The following is a description of a gene set: Mouse Gene Set: GOBP_CELLULAR_RESPONSE_TO_ENDOGENOUS_STIMULUS Any process that results in a change in state or activity of a cell (in terms of movement, secretion, enzyme production, gene expression, etc.) as a result of a stimulus arising within the organism. studied in species Mus musculus, and this is the list of marker genes: Fam114a1, Wnt7a, Hcrtr2, Cnot1, Tgfbr3l, Nucb2, Ctbp2, Ubr5, Etv2, Cdc5lrt8, Mtcl2, Uba5 (ubiquitin-like modifier activating enzyme 5), Camk2a, Ceacam2, Itga8, Lrrc32, Lrp8, Glp1r, Tyk2, Smurf2, Col1a2, Heyl, Rock2, Fbxl15, Kcp (NCBI Gene Id 333088), Ywhag, Hmga1, Socs3, Pak1, Nr3c1, Crh, Pkm, Pgr, Ros1, Crim1, Smurf1, Ehd4, Scnn1b, Lrit3, Raf1, Abhd2, Etnppl (ethanolamine phosphate phospholyase), Col4a2, Fermt1, Sphk1, Grem1, Mir486, Fgf7, Ffar3, Reg1, Hyal2, Pdgfb (platelet derived growth factor, B polypeptide), Gpt, Cga (NCBI Gene Id 12640), Daxx, Itgb6, Ero1a (endoplasmic reticulum oxidoreductase 1 alpha), Strap, Flrt2, Neo1, A1bg, Pck1, Gpr155, Ptk2, Mst1r, Rab35, Ncoa1 (NCBI Gene Id 17977), Gpr21, Ptprf, Ireb2, Ngly1, Mir23a, Msx1, a, Cdc5lrt10, Zmpste24, Gpc1, Foxc1, Cav2, Jak3, Rbm14, Gdnf, Gdf6, Greb1l, Ghsr, Vsir, Ptger2, Casp9, Lep (NCBI Gene Id 16846), Cckar, Cyp1b1, Npffr1, Ctnnb1, Ncor2, Lats2, Mir206, Anxa1, Fkbp4, Dlx1, Lpin1, Stat5b, Nkx2-1, Pdpk1, Mir675, Adam17, Csrp3, Prkcb, Rap1gap, Irs1, Comp, Uchl3, Ccn1, Zfp703, Pde4d, Opa1, Rab14, C2cd5 (NCBI Gene Id 77314), Actr3, Ucp2, Pagr1a, Spry2, Aldh1a2, Stat3, Slit3, Agtr2, Rhoq, Sstr2, Ltk, Prmt2, Tmf1, Grem2, Ccl5, Rela, Klf4, Sik2, Sp1, Twist1, Trarg1, Trp63, Mertk, Sfr1, Fgf17, Dand5, Atp5f1a, Rarb (retinoic acid receptor, beta), Ephb1, Magi2, Rxrb, Ppara, Cdkn2b, Ifnb1, Aspn, Park7, Mup5, Mus81, Ppard, Rasl11b, Bmi1, Ppp3ca, Dbn1, Rps6kb1, Gclm, Tmem100, Fgf20, Chrd, Sos2, Bmpr1b, Hmgcs2, Wnt1, Sh3gl2, Socs7, Fez1, Spred1, Atf2, Kdm6a, Adam9, Cnot3, Lancl2, Pip4k2c, Cflar, Appl2, Mir219a-2, Wasf1, Veph1, Bex1, Tmem108, Cpeb1, Mir207, Ugt1a6a, Igf2, Mir297-1, Gnai2, Chst11, Dnaaf4, Zdhhc17, Irs3, Gcg (NCBI Gene Id 14526), Mir125a, Yes1, Dkk1, Mup3, Tmprss6, Gpr150, Acap2, Adrm1, Mgarp, Pik3r2, Bmpr1a, Col6a1, Socs2, Lemd2, Itga3, Pitx3, Cst11, Hnrnpu, Zeb2, Ark2c, Epha5, Ddr2, Car2, Blvrb, Fuz, Gab1, Becn1, Rgmb, Il12b, Clock, Acvr1, Ppargc1a, Crebbp, Sost, Dcn, Srebf1, Lncbate10, Mir219a-1, Nr5a1, Slc27a4, Mcm7, Flcn, Zfyve27, Kdm5b, Ahsg, Cul7, Ndst1, Aqp1, Prkaa1, H2az1, Tgif1, Il17f, Lbh (limb-bud and heart), Robo1, Ctsh, Wfikkn1, Lrp1 (NCBI Gene Id 16971), Ntf3, Csnk1e, Tab1, Efna5, Gria2, Fgf3, Ddx17, Inhbb, Snx25, Elapor2, Adamts7, Peg10, Mn1, Usp8, Lpin2, Mir145b, Ufsp2, Epha8, Nr5a2, Kif16b, Kmt2e, Acbd7, Pou4f2, Vdr, Bglap3, Slc2a4, Cd109, Npas4, Spry1, Zfp128, Cdkn1c, Vtn, Il12a, Fgf15 (fibroblast growth factor 15), Lpxn, Rack1, Phex, Notch1, Cd59a, Zbtb7a, Il17a, Mapk1, Furin, Creb1, Acvr2a, Mef2c, Acvr2b, Ep300, Rhoa, Mir138-2, Phox2b, Trim63, Bmal1, Foxh1, Med1, Calcoco1, Mirlet7f-2, Smarcc1, Zdhhc16, Zfp451, Megf8, Zfyve9, Fkbp1a, Mirlet7e, Smpd3, Iqgap1, Mir192, Nr4a1, Rangap1, Safb, Sstr5, Ints9, Akap8 (NCBI Gene Id 67462), Cat, Cnmd, Zmiz1, Fbp1, Ski, Fzd1, Or51e2, Socs1, Safb2, Hnrnpk, Zcchc12, Pdgfra, Snw1, Vamp2, Ghr, Sos1, Taf7, Dsg4, Cxcl13, Gdf15, Tgfbr3, Slc2a10, Mir195a, Micall1, Prkcq, Cul3, Brms1, mt-Nd3, Mir181d, Acsl1, Ufm1, Lats1, Ndnf, Cad, Mir125b-1, Npffr2, Nr2c1, Nr4a3, Esr1, Rara, Mir708, Epha1, Dnai1, Ext2, Mir494, Nr1d2, Fbn2, Git1, Tgfbr2, Xcl1, Mir338, Gprin3, Ramp3, Hhip, Mup1, Pde3b, P2ry4, Pdcd5-ps, Kit, Flrt3, Spon2, Gdf3, Zfp764, Pin1 (peptidyl-prolyl cis/trans isomerase, NIMA-interacting 1), Gck, Pax9, Epha2, Kat2a, Zfp747l1, Itgb5, Sox5, Cyfip1, Ptprd, Ngf, Rb1, Fam20c, Ppp1r9b, Usp26, Phb1, Rarg, Cdc5l, Tns2, Mirlet7b, Ramp1, Frs2, Selenon, Snx6, Lrg1, Dstyk, Lef1, Mir147, Hgf, Lrp2, Brca1, Kank1 (KN motif and ankyrin repeat domains 1), Kat2b, Itgb1bp1 (NCBI Gene Id 16413), Eif4e, Sra1, Ptgdr, Arid4b, Ing1, Pde3a, Fech, Braf, Parp1, Cd63, Hoxa13, Ntf5, Has1, Sva, Hjv, Nedd4, Cdc5lrt1, Tob1, Arid1a, Klb, Th, Nodal, Bcar1, Otop1, Cdh3, Adamtsl2, Pdk4, Hes1 (hes family bHLH transcription factor 1), Avpr2, Asns, Ift80, Rasa1, Rps3, Nrxn1, Cav3, Map2k5, Bmp5, Stub1, Zeb1, Map3k1, Adra2a, Trp53, Rac1 (Rac family small GTPase 1), Atp7a, Ext1, Skor2, Padi2 (NCBI Gene Id 230871), Agtrap, Ncf2, Baiap2, Sox6, Cited2, Acta2, Prkaca, Ncoa2, Pax8, Vps54, Tcf7l2, Gphb5, Foxd1, Ptprj (NCBI Gene Id 98976), Casr, Tnfsf4, Crhr2, Xbp1 (X-box binding protein 1), Lepr, Epn2, Cyp7b1, Srarp, Bbs2, Cask, Foxo1, Ptpn12, Cry2, Cer1, Hmga2, Mir493, Prkca (NCBI Gene Id 18750), Prdm14 (PR domain containing 14), Scnn1g, Gata5, Smoc2, Ncor1, Rab31, Sap30, Arap1, Cyp26a1, Ucp3, Coro1b, Mmrn1, Lgals9, Epha7, Erbb4, Sgk1, Pelo, Cep57, Ptpn2, Fbxo32, Ccbe1, Ecsit, Gdf2, Ntrk3, Ntrk2, Bmncr, Gfra1, Onecut2, Adissp, Oxtr, Sst, Mir103-1, Tac1, Wt1, Crkl, Nrp2, Emd, Fam89b, Adipor2, Dnmt1, Ogt, Stxbp4, Akt1, Dll1, Blvra, Npnt, Npc1, Cadm4, Sgcb, Dlx5 (NCBI Gene Id 13395), Fgf21, Churc1, Nr1h3, Ptgfr, Myo5a, Fgf12, Vps18, Leprotl1, Vps11, Mup2, Myog, Tmem204, Naip1, Ddx5, Mkks, Foxo4 (forkhead box O4), Sox10, Akr1c19, Stmn2, Smad9, Mir148a, Mir142, Gata4, Tnrc6c, Axin2, Fgf4, Map1b, Cdc5lrt7, Cuzd1, Ppp5c, Abl1, Notch2, Bloc1s6, Zfp764l1, Mup11, Smad7, Rab13, Sstr1, Cited1, Ilk, Jun, Acvr1b, Irf1, Gnrhr, Gstp1, Nfe2l2 (NCBI Gene Id 98874), Ncl, Tnfaip6, Ins1, Atp2b1, Mir26b, Ndel1, Epha6, Fgf16, Pax6, Sorl1, Cdh5, Pxn, Cib1, Ptpre, Glp2r, Rhod, Insrr, Gata6, Bambi, Vwc2l (NCBI Gene Id 320460), Mtmr4, Shc1, Pten, Fgfrl1, Cdc5lrt5, Cripto, Zfp36l2, Rxfp1, Rnf14, Ptprv (NCBI Gene Id 64447), Map3k7, Thrb, Slc2a8, Cidea, Scgb2a2, Osbpl8, Lmtk2, Cx3cr1, Dlx3, Phb2, Ndn, Nck1, Ctsd, Ret, Fosb, Nr1d1, Hif1a (hypoxia inducible factor 1, alpha subunit), Wfikkn2, Dnaja1, Dll4, Tbc1d4, Akt2, Il4, Fgfr2, Mir145a, Mstn, Sstr3, Fkbp8, Pik3cb, Crhbp, Mir122, Trim68, Enpp1, Akap13, Slc39a14, Gh, Brd8, Ripk1, Marcks, Pdcd6, Spart (NCBI Gene Id 99725), Akr1c18, Cd2ap, Phip (NCBI Gene Id 83946), Lmo3, Hspb1, Src, Ugt1a6b, Agtr1a, Ankrd26, Ren1 (renin 1 structural), Ptges3, Ang2, Fgf23, Itgb3, Tfap2b, Alk, Cldn5, Plcb1, Fgf5, Runx1, Lpin3, Knstrn (kinetochore-localized astrin/SPAG5 binding), Adgra2, Tgfb2, Avpr1b, Flt1, Carm1, Itgb1, Gria1, Akr1c13, Axin1, Lox, Usf1, Usp15 (NCBI Gene Id 70921), Eef1a1, Ptpn1, Ofd1, Hes5, Mapk3, Ppp2r5b, Pdcd5, Gsk3b (NCBI Gene Id 98033), Ostn, Mir138-1, Ccna2, Mir16-1 (NCBI Gene Id 387134), Rbx1, Fgfr3, Hdac9, Ugt1a1, Sirt1, Chrdl1, Ace, Dmd, Cyp11b1, Cpne3, Spred2 (sprouty-related EVH1 domain containing 2), Prkar1a, Fgf2, Kidins220, Pkd2, Nsmf, Eif4ebp1, Spi1, Ltbp1, Stk16, Prkd1, Cacna1a, Tmem119, Apc, Myof, Thra, Rxra (retinoid X receptor alpha), Sap30l, Obp2a (odorant binding protein 2A), Atp2b4, Mfn2, Serpine1, Tmem53, Sfrp2, Itga5, Zpr1, Fgb, Gcnt2, Brms1l, Epha10, Hdac2, Ibsp, Map2k1, Bmp2, Itgb8, Slc9a1, Arpc2, Mettl21c, Rbpms2, Hif1an, Kmt2a, Ryr1, Hap1, Flt3, Zfp747 (NCBI Gene Id 269997), Egfr, Nono, Errfi1, Dync1li2, Esrra, Cyp26b1 (NCBI Gene Id 232174), Adcy6, Slc25a33, Kdm4c, Brip1, Avpr1a, Uri1, Lhcgr, Dab2, Bag4 (BCL2-associated athanogene 4), Ube2o, Pbld1, Stc1, Elavl4, Pik3ca, Rbbp7, Slc27a1, Ass1, Ulk1, Ube3a, Naip2, Numa1, Dcp1a, Akt1s1, Trim33, P2ry6, Tcf4, Echdc3, Csnk2b, Smad2, Igfbp1, Usp9x, Tfpi, Wnt10a, Rock1, Mbd5, Tsc22d1, Cdc5lrt6, Adcyap1, Pdcd4 (programmed cell death 4), Nkx3-1, Nrp1, Bcl9l, Prmt1, Fgf9, Jcad, Mir21a (microRNA 21a), Pak2, Ctsk, Bglap2, Angpt1, Tbx2, Spint1, Rbpj, Grb2 (growth factor receptor bound protein 2), Ucp1, Bmp4, Pdgfrb, Pck2, Prdm16, Zfp106, Wdtc1, Nr3c2, Nlk, Hyal1, Rab10, Arid5a, Arrb2, Ugcg, Crk, Eprs1, Prlr, Hrg, Alpi, Adamts3, Mir143, Mirlet7a-1, Dhrs3, Kl, Stk11, Adcy8, Fgf10, Rarres2, Dtymk, Hsp90ab1, Abcb1a, Ncoa5, Pmepa1, Vegfd, Kbtbd2, Tnc, Crhr1, Ptp4a3, Klf9, Fbxw8, Ppp2r5d, Uso1, Fgf22, Star, Cyp11a1, Rap1gds1, Srsf3, Anxa5, Mirlet7f-1, Cfl1, Cdk2, Smyd3, Il18, Agrp, Fgfr4, Cldn18, Foxc2, Bmp7, Bmp6, Cry1, Ptpn11, Cyfip2, Zyx, Naip6, Pals1, Sesn3, Fst, Ppm1a, Adamts12, Wnt2, Plk5, Smarca4, Nr4a2, Erbb2, Axl, Hspa5, Foxa1, Nr1h2, Zfp592, Stat5a, Vegfb, Actn4, Epha3, Fam107a, Wwox, Ephb3, Flt4, Ccn2, Fat4, Kdm3a, Atp1a1, C1qtnf12, Crebrf, Adipoq, Egr3, Fstl3, Ing2, Hras (NCBI Gene Id 15461), Fgf6, Postn, Msx2, Fgf18, Trim71, Smc1a, Il17rd, Eid2, Nptn (NCBI Gene Id 20320), Nr0b1, Spred3, Appl1, Vasn, Folr1, Fyn, Lgmn, Pim1, Per1, Sulf1, Gpld1, Mir329, Pde8a, Cdc5lrt9, Htra3, Got1, Hfe, Rxrg, Erfe, Fut8, Fgfbp1, Tlr4, Tspan32, Sdcbp, Tgfb1, Wnt4, Prkd2, Tbx20, Grb14, Acod1, Sh3glb1, Kdr, Tgfbr1, Snx5, Suds3, Smad1, Ucn2, Rnf6, Capn10, Sox11, Ednra, Bbs4, Smad4, Skor1, Ddr1, Fgf1, Foxp1, Nog, Slc4a7, Pid1, Ehd1, Scube3, Shisa2, Igfbp2, Sorbs1, Sin3a, Dab2ip (NCBI Gene Id 98996), Cstf2, Gdf5, Fut7, Casp3, Igf1r, Actn2, Strn3, Rbfox2, Ltbp3, Ywhah, Kcnd3, Inpp5k, Hdac1, Apaf1 (NCBI Gene Id 76129), Nos3, Cilp, Sort1, Shcbp1, Frs3, Musk, Mir466, Fer, Snai2, Sparc, Coro1a, Kmt2d, Insr, Ezh2, Ngfr, Tnf, Dennd4c, Acvr1c, Rwdd1, Bcar3, Tek, Mapkapk2, Gpam, Grb7, Bmpr2, Gnas, Nkx6-1, Sox9, Jak1, Cyp27b1, Slc30a10, Cldn1, Ggcx, Lhx1, Met, Prkcz, Slc9a6, Tshr, Pik3r1, Slc39a5, Mir155, Prkdc, Cnot9, Csk, Zfp36, Chrdl2, Glg1, Eif4ebp2, Spry4, Dync1li1, Rap1a, Grip1, Twsg1, Fstl5, Gata3, Cnot2, Flrt1 (NCBI Gene Id 396184), Gclc, Prokr1, Zfp423, Ppargc1b, Kank2, Edn1, Lonp1, Aifm1, Bglap, Trim24, Myo1c, Il6, Fam83g, Prkaa2, Htra2, Fshb, Xdh, Mas1, Ern1, Zfp36l1, Runx2, E2f1, Ctdspl2, Arid4a (AT-rich interaction domain 4A), Gas6, Tie1, Fstl1, Mzb1, Penk, Epb41l5, Gipc1, Pgf, Agtr1b, Bmp8a, Angpt2, Gsk3a, Oprd1, Qrfpr, Mir210, Ccl2, Grb10, Il10, Col1a1, Aldh1a3, Trerf1, Ins2, Cbl, Foxo3, Dnm2, Sfrp1, Sinhcaf, Dcstamp, Cdc5lrt4, Sulf2, Gpr173, Leprot, C1qtnf9, Ghrhr, Stat6, Cav1, Sh2b2, Zfp536, Nbl1, Calr, Gkap1, Nfix, Rdx, Slit2, Gper1, Eme1, Wnt10b, Nus1, Tyro3, Mdm2, Wnt3a, Trpv1, Insig1, Thbs1, Akr1c12, Esr2, Trim72, Nucks1, Gcgr, Rapgef2, Shoc2, Fbh1, Fshr, Hivep1, Map2k3, Bcas3, Dusp22, Mir126a, Bmp10, Hsf1, Tet1, Smad5, Fgfr1, Nepn, Trib3, Gata1, Sirt6, Agt, Ndp, Acvrl1, Skp2, Prkce, Ar, Nfia, Tgfb1i1, Hipk2, Plcg1, Tsc2, Col3a1, Insig2, Rapgef1, Cps1, Pik3r3, Ptger4, Gpr22, Myod1, Apln, Rbm4, Sco1, Dok5, Mir18, Egr1, Bmp8b, Pbld2 (NCBI Gene Id 67307), Adgrg1, Crb2, Htra1, Gdf7, Vegfa, Irs4, Ptprk, Ide, Sfrp4, Mir451a, Smad3, Hcrtr1, Il1b, Inhba, Id1, Prl, Nrros, Vwc2, Pin1rt1, Syap1, Jak2, Qrfprl, Trh, Snx1, Emilin1, Vstm2a, Eng, Max, Wbp2, Slc26a6, Has2, Mup4, Nr1h4, Grk2 (G protein-coupled receptor kinase 2), Onecut1, Pklr, Skil, Vegfc, Mapk14, Smad6, Hpgd, Nrep, Rest, Hgs, Wnt5a, Rgma (NCBI Gene Id 244058), Mir146, Ptpra, Bdnf, Prokr2, Trip4, Myocd, Fgfbp3, Klf2, Pml, Fstl4 (NCBI Gene Id 320027), Ankrd1, Mtor, Gad2, Amhr2, Vil1, Csf1r, Ephb4, Pik3cd, Nfkbiz, Ror2, Prcp, Scx, Ucn3, Ovol2, Mt3, Kdm5d, Sstr4, Adipor1, Ephb2, Calca, Gja1 (gap junction protein, alpha 1), Slx4, Fbn1, Rps6kb2 (NCBI Gene Id 58988), Sema6a, Twf2, Fos, Epha4, Mtss2, Mir223, Pdk2, Zbtb7b, Ufl1, Pias2, Isl1, Tigar, Pcsk9, Arf6, Mapk7, Ddrgk1, Ltbp4, Ptf1a, Garem1, Fgf14, Gpc3, Prkcd, Mars1, Ddit4, Pkd1l1, Cyp11b2, Bmper, Pdgfd, Ctsb, Umodl1, Prkci, Mir574, Tmem107, Rnf111, Ntrk1, Vwa2, Ocstamp, Asxl1, Tbx1, Men1, Shq1, Serpina12, Mapkap1, Zfp366, Inppl1, Irs2, Sap130, Esrrb, Esrrg, Lpl, Ncoa3, Cpeb2, Creb3l1, Mir103-2, Ceacam1, Mir672, Zdhhc7, Fermt2, Pelp1, Tcf21, Ramp2, Eef2k, Rbbp4 (retinoblastoma binding protein 4, chromatin remodeling factor), Col2a1, Acaca, Dlg1, Fgf8, Serpinf1, Ahcyl1, Mmrn2, Pip4k2b, Lemd3, Hhex, Pip4k2a, Pparg, Nanog, Tgfb3, Igf1, Scnn1a (sodium channel, nonvoltage-gated 1 alpha), Rxfp2, Fzd4, Rab8a, Nos1, Tnfrsf1b, Hdac6, Sostdc1, Ldlrad4, Gjb2, Cd44, Akt3, Dusp3, Ube2l3, Mirlet7d, Nfkb1, Atp1a2 (NCBI Gene Id 98660)